The following is a description of a gene set: species: Homo sapiens Human Gene Set: TTGCCAA_MIR182 Genes having at least one occurence of the motif TTGCCAA in their 3' untranslated region. The motif represents putative target (that is, seed match) of human mature miRNA hsa-miR-182 (v7.1 miRBase)., and this is the list of marker genes: VLDLR, GPR85, PLPPR4, MOB1B, ADD3, GOLGA8A, ARHGEF3, PRDM1, NPM1, ZNF280B, CORO1C, TOB1, DOCK9 (dedicator of cytokinesis 9), FAM171A1, MAP1LC3B, FGF9, ABCC3, RHOBTB1, ATAT1, ATOH8 (atonal bHLH transcription factor 8), MMD, ATXN1, MYADM, NADK2, N4BP1, SAMTOR, SELENOI, SP3, HOXA9, VAV2, EDNRB, PCDH8, TACC1, ZFP36L1, TMEM47, SS18L1, CLPTM1L, SH3BP4, PRP4K, PPP3R1, DSCAM, RALGAPB (NCBI Gene Id 57148), SMAD1, L1CAM, MEF2C, FXR1, KHDC4, CITED2, WASF2, EIF5, RNF44, LSM14A, CD47, CADM2, RIMBP2, CLOCK, RDX, FBXW11, AKAP7, PPP1R2, PPP4R3A, FOXO3, SATB2, MTSS1 (NCBI Gene Id 9788), ADAM10, SKAP2, LHX3, WDR47, TNRC6B, YWHAG, ARGLU1, CUL5, MTURN, ZFP36, DR1, PLD1, PLCH1, DYNC1LI2, PRRX1, EGR3, RASA1, ABTB3, RET, ELL, SLC44A2, XPR1, DENR, MBNL2, AEBP2, PABIR1, RGS17, QKI, CD2AP, STARD13, DENND6A, ADCY2, C2CD2, BDNF, ZMPSTE24, KHDRBS3, PCMT1, MSL2, MAK, PHF21A, MMP16, PPM1E, GMFB, PYGO2, DYRK1A, PCGF3, RPRD1B, BNC2, SGMS1, CCNJ, BCL2, NUFIP2, PHF13, TEX2, MVB12B, SLITRK4, WSB1, GABBR1, RAB6B, HYCC2, FLOT1, UBXN10, KLF7, PRKACB, FNBP1L, FEM1C, APLN, EFNB2, ZNRF1, UBE3C, NPTX1, TP53INP1, MYO19, KDELR1, TXNL1, VPS26B, ARHGEF7, RAB10, XBP1 (X-box binding protein 1), BACH2, ZFC3H1, ISL1, GIT2, JAZF1 (NCBI Gene Id 94314), MITF, ZC3H15, RAC1, MFAP3, PRKD1, C9orf72, ABLIM1, ACVR1, TOPBP1, TP53INP2, POLR2M, FOXF2, EBF3, PPIL1, TSNAX, ATP1B3, GEMIN8, NKX2-2, SLC39A9, SLC1A2, BCL2L13, FMR1, FOXN3, SLC4A7, KDM2B, YAF2, PCMTD1 (protein-L-isoaspartate (D-aspartate) O-methyltransferase domain containing 1), ETS2, ADCY6, UBE2R2, ZFAND4, HOXA10, WIPI2, ANK3, NFASC, RETREG1, NRCAM, CNOT6, SETD7, RNF144B, ANK2, CCDC117, MAF, ADRA2C, KPNA3, ACACA, GOLGA8EP, MARK3, SPRY4, RIMS3, PRUNE2, MAGI1, EVI5, EXOC4, CBFA2T3, KCMF1, GK, SHC4, MEF2D, SEPTIN7, SCRT1, CAMTA1, AJUBA (NCBI Gene Id 84962), NAP1L1, SH2D1A, CDV3, ARMC1, MTCH2, PIGA, ARHGDIA, SYPL1, DCUN1D4, TMEM115, NUMB, MEIS2, IGSF3, NCALD, SNX4, RALGDS, MARCKS (NCBI Gene Id 4082), TMEM50B, TSPAN9, FZD3, TAPT1, GRM5, IRF2BPL, P2RX4, PCDH17, TRIM8, OGT, UBE2Q2, TMEM145, DCUN1D1, FNDC3B, PCNX2, ELL2, ATP2A2, ZCCHC14, NUAK1, NSD3 (nuclear receptor binding SET domain protein 3), INTS6, PAFAH1B1, HMGCLL1, EPAS1, NSD2, KLF13, CSNK1E, BHLHE22, PALLD, CDC27, CFL1, PREPL, VAMP3, CTTN, BRMS1L, DCAF12, PCDH18, GOLGA8G, ADGRL2, EPM2A, STOX2, TBC1D22A, EPHB1, RARG, ADAMTS18, ABHD13, NTNG1 (NCBI Gene Id 22854), SLC43A2, TMEM68, DOK4, SOX2, EIF3A, CELF6, WIPF1, KTN1, ERC2, BCL2L12, BAG4, RNF208 (NCBI Gene Id 727800), BHLHE41, KIAA1217, PDXDC1, PTHLH, LIMK1, FBXW7, INSIG1 (insulin induced gene 1), PRRG3, IP6K1, CNPY3, FAM78A, PARM1, CEBPA, EPHA7, AGO1, AUP1, MCMBP, THBS2, AMMECR1L, ARRDC3, PAIP2, SNAP23 (synaptosome associated protein 23), DAZAP2, BCL11A, CHMP1A, FAM91A1, VASP, SPRTN (NCBI Gene Id 83932), KMT2A, BABAM2, PC, DMXL1, RTN4, TAF15, SEPTIN9, PDZD4, ARF4, ELMO1 (NCBI Gene Id 9844), KLF15 (KLF transcription factor 15), OCRL, PBX2, CAMSAP2